The following is a description of a gene set: Human Gene Set: WP_HOSTPATHOGEN_INTERACTION_OF_HUMAN_CORONAVIRUSES_INTERFERON_INDUCTION Host-pathogen interaction of human coronaviruses - interferon induction species: Homo sapiens, and this is the list of marker genes: IKBKE, NFKBIA, NFKB1, TBK1, TYK2, IFNAR2, STAT1, STAT2 (signal transducer and activator of transcription 2), MYD88, TICAM1, IFIH1, MAPK14, JUN, RIGI, IRF3 (interferon regulatory factor 3), IKBKG, MAP3K7, IKBKB, OAS3, FOS, MAPK8, OAS2, MAVS, TRAF3, CHUK, TLR7, TRAF6, RIPK1, IFNAR1, EIF2AK2, OAS1, IRF9, JAK1